The following is a description of a gene set: Mouse Gene Set: chr7E1 studied in species Mus musculus, and this is the list of marker genes: Emsy, Thrsp, Rab30, 4930567K12Rik, Sytl2, Gm32647, Crebzf, 6430511E19Rik, Gm16938, Tmem126a, Snord15a, Gm26944, Rsf1, Gm19656, Ndufc2 (NADH:ubiquinone oxidoreductase subunit C2), Mir326 (NCBI Gene Id 723840), A630091E08Rik, Slco2b1, Gm15501, Acer3, Pcf11, Gdpd4, Aamdc, Gm15413, Map6, Gm34280, Gm8398, 4632427E13Rik, Gm24552, Capn5, Gm5037, Mir708, Gdpd5, C030038I04Rik, Ddias, Gucy2d, Nars2, Rsf1os1, Alg8, Gm15412, Kctd21, Ccdc83, Neu3, Dgat2, Gab2, Gm10605, Ywhaq-ps1, Kctd14, Ints4, 4931412I15Rik, Gm45162, Gm44507, Gm23928, Aqp11, Tmem126b, Rps11-ps5, Clns1a, Gm2926 (NCBI Gene Id 100044607), Gm22226, Mogat2, A930002H02Rik, Gm44978, Bc1-ps1, Usp35, Gm24412, Gm25860, Mir6394, Gm23040, Lrrc32, Fam181b, Ccdc89 (coiled-coil domain containing 89), Gm31663, Thap12 (THAP domain containing 12), Myo7a, Rpl15-ps5, Or2at1, Omp, Klhl35, Gm33882, Tpbgl, Arrb1 (arrestin, beta 1), Dlg2, Gm57488, Gm8309, Rps3, Gm25409, Pak1, Ccdc90b, Gm18943, Snord15b, Gm5899, Gm23479, B3gnt6, Gm19182, Tsku, Gm19761, Gm9934, Serpinh1, Gm8319, F730035P03Rik (RIKEN cDNA F730035P03 gene), Prcp, Gm8285, B230206I08Rik, Uvrag, Wnt11, Ankrd42, Or2at4, Tenm4, Gm26705, Gm18197, Rsf1os2, 9530078K11Rik